Given this list of marker genes ABHD17B, TMEM71, ANXA2, PDE4B, HLA-G, LSP1, SPATA6, PCBP4, CERS6, CEP55, WFS1, TMEM106A, FRK, INPP4A, RND2, RCSD1, AKR1B10, MTHFR, TCIRG1, RDH12, FMNL2, EPOP, ELMO1, LCP2, VASH2, INSYN2A, WDFY2, SORL1, NXN, SWAP70, CHDH, ANO6, EXPH5, EFCAB14, SLC25A23, TPD52, ALDH5A1, TNRC18 (NCBI Gene Id 84629), SH2B2 (SH2B adaptor protein 2), HLA-DOA (NCBI Gene Id 51034), IRF8, PHGDH, CCL4, GATA3, AP1S2, EVA1B, CDK14, FSTL1, PARP14, IL11RA, SMAD1 (SMAD family member 1), ITIH5, KANK2, SLC39A11, STING1, MED13L, HSD17B11, HPCAL1, ZFAND3, WDR45B, RNF24, LY86, DOCK2, PDE8A, EDEM2, MPND, AMZ1, CRYBG3, PDCD1LG2, FGD2, IFT88, CCR2, FUT7, CBFA2T2, SPP1, CHSY1, NAGK, MAP3K8, DENND2D, ADCY4, MYO5C, RERE, B4GALT5, HDAC6, BTLA, STMN1, MITF, ANO10, TMEM204, STAT4 (signal transducer and activator of transcription 4), HEXA, OAS1, NRP1, SESN1, PLCXD2 (NCBI Gene Id 257068), DYNLT2B, GLIS3, TMEM119, RGS18, C11orf54, P3H3, RRAS, TFEC, PAK1, GSAP, SELENON, CALCRL, BEX1, GHR, EGLN3, SLC16A13 (solute carrier family 16 member 13), IFITM3, PNRC1, APOBR, OSBPL9, BAZ2B, DOCK8, FKBP1B, KAZN, FYCO1, CEP68, ANXA4, MAST3, CYRIA, TLR4, TP53I13, C1R, FRMD6, DIAPH2, HERC3, NIM1K, EMCN, TXNIP, DUBR, SALL2, ARHGAP25, FAM167B, PXYLP1, MYLIP, SH3KBP1, WTIP, SPATA13, TIPARP, ISLR, TM4SF1, CCDC122, PGLYRP2, CTDSPL, TXNDC12, TGFBI, UNC93B1, MEIS1, C1orf54, DOCK1, ARPC1B, CFP, INPP5K, IQGAP2, ZNF764, MGAT5, ZNF229, EBPL, CD37, UBASH3B, PXDN, SLFN12L, MCF2L (MCF.2 cell line derived transforming sequence like), DGAT2, TM6SF1, MAMDC2, EXTL2, CORO1A, RNASE6, PPP1R13B, PYCR1, TMCC2, PADI2, AKR1B1, FILIP1L, LPAR6, ACOT11, NAV1, CAMKK1, FAH, MYOM1, CYP7B1, KLK8, NCKAP1L, LPP, VSIG2, IFI44, RASGRP2, TBC1D1, FBXO21, CARD19, TIGAR, ARHGAP31, SEPTIN10, RECK, CBX6, here is a description of the gene set: studied in species Homo sapiens from publication Yusuf I, Kageyama R, Monticelli L, Johnston RJ, Ditoro D, Hansen K, Barnett B, Crotty S (PMID 20525889) Genes up-regulated in CD4 T cells: non-Tfh versus Tfh (T follicular helper). Human Gene Set: GSE21380_NON_TFH_VS_TFH_CD4_TCELL_UP CD4 T cell help is critical for both the generation and maintenance of germinal centers, and T follicular helper (TFH) cells are the CD4 T cell subset required for this process. SAP (SH2D1A) expression in CD4 T cells is essential for germinal center development. However, SAP-deficient mice have only a moderate defect in TFH differentiation as defined by common TFH surface markers. CXCR5+ TFH cells are found within the germinal center as well as along the boundary regions of T/B cell zones. Here we show that germinal center associated T cells (GC TFH) can be identified by their co-expression of CXCR5 and the GL7 epitope, allowing for phenotypic and functional analysis of TFH and GC TFH populations. Here we show GC TFH are a functionally discrete subset of further polarized TFH cells, with enhanced B cell help capacity and a specialized ability to produce IL-4 in a TH2-independent manner. Strikingly, SAP-deficient mice have an absence of the GC TFH subset and SAP- TFH are defective in IL-4 and IL-21 production. We further demonstrate that SLAM (Slamf1, CD150), a surface receptor that utilizes SAP signaling, is specifically required for IL-4 production by GC TFH. GC TFH cells require IL-4 and IL-21 production for optimal help to B cells. These data illustrate complexities of SAP-dependent SLAM family receptor signaling, revealing a prominent role for SLAM receptor ligation in IL-4 production by germinal center CD4 T cells but not in TFH and GC TFH differentiation.